Given this list of marker genes AKT2, ENPP1, PPP1R3G, GRB10, PPP1R3D, IGF1, IRS1, PRKAG3, GBE1, PPP1R3E, UGP2, PER2 (period circadian regulator 2), EPM2AIP1, AKT1, NHLRC1, GYS2, INSR, GYG1, PASK, INS, SORBS1, PTH, PPP1R3B, PPP1R3A, MIR15B, AGL, EPM2A, IRS2, IGF2, NR1D1, ACADM, MIR1271, GSK3A, GCK, PPP1CA, MIR195, DYRK2, PGM2, INPP5K, PPP1R3F, SELENOS, GYS1, GSK3B, GYG2, PPP1R3C, here is a description of the gene set: The chemical reactions and pathways resulting in the formation of glucans, polysaccharides consisting only of glucose residues. studied in species Homo sapiens Human Gene Set: GOBP_GLUCAN_BIOSYNTHETIC_PROCESS